Given this list of marker genes PARP15, CDS1, PARP3, MED21, POLR2L, TENT2, POLA1, POLR3G, TUT7, ART5, CGAS, OASL, POLR3B, PRIM1, PARP11, PARP8, CRCP, TERF1, MAB21L1, POLH, PARP12, TNKS, PTGES3, CRPPA, PCYT2, PINX1 (PIN2 (TERF1) interacting telomerase inhibitor 1), OAS3, TEN1, UVSSA, ART4, TENT5D, ART1, GPHN, TENT5C, FLAD1, POLR2J3, MB21D2, TRNT1, SIRT4, POLR2J2, PAPOLB, NMNAT2, PNPT1 (polyribonucleotide nucleotidyltransferase 1), CTU1, YRDC (NCBI Gene Id 79693), SELENOO (selenoprotein O), GMPPB, POLE, GMPPA, CTU2, DNTT, RPAP1, FICD, PCYT1B (NCBI Gene Id 9468), POLN, POLE2, POLD4, PAPOLG, NMNAT1, PARP6, UAP1, POLD1, GDPGP1, POLD3, TNKS2, PIF1, TEP1, POLR2H, REV1, REV3L, GALT, POLE3, NMNAT3, DDX21, POLE4, POLR2J, POLG, POLR2I, PAPSS2, UAP1L1, POLR1H, POLR1D, MOCS3, ART3, RNGTT, POLR2F, POLR2B, POLR3C, MCRS1, PARP16, TERF2, TENT5B, MED20, TEFM, PARP4, OAS1, ACD, TERT, POLK, PRIMPOL, PARP9, COASY, FHIT, PCNA, POLI, MTPAP, ABL1, THG1L, POLM, POLR3F, POLR1A, GARS1, DKC1, PARP2, POLRMT, PARP14, POLR1C, POLR3H (NCBI Gene Id 91605), CDS2, FPGT, OAS2, TAMM41, POLG2, POLQ, TENT4A, TENT5A, SIRT6, CHRAC1, POLR2A, TUT4, PRIM2, POLR3A, ERCC4, POLR2E, TUT1, CMAS, POLB, TENT4B, PARP10, PARP1, KARS1, POLR1B (RNA polymerase I subunit B), PCYT1A, POLL, TERC, POT1, POLR3K, PAPSS1, UGP2, TIPARP, POLR2C, PAPOLA, POLR2K, NUDT5, here is a description of the gene set: studied in species Homo sapiens Human Gene Set: GOMF_NUCLEOTIDYLTRANSFERASE_ACTIVITY Catalysis of the transfer of a nucleotidyl group from one compound (donor) to another (acceptor).